The following is a description of a gene set: Any process that modulates the rate, frequency or extent of release of cytochrome c from mitochondria, the process in which cytochrome c is enabled to move from the mitochondrial intermembrane space into the cytosol, which is an early step in apoptosis and leads to caspase activation. Mouse Gene Set: GOBP_REGULATION_OF_RELEASE_OF_CYTOCHROME_C_FROM_MITOCHONDRIA species: Mus musculus, and this is the list of marker genes: Bax, Moap1, Opa1, Pycard, Trp53, Pdcd5, Mfn2, Hgf, Bcl2l11, Lmna, Mff, Prelid1, Psmd10, Wdr35, Avp, Ppif, Hrk, Bak1, Fxn, Mllt11, Higd1a, Nol3, Fas, Bad, Pdcd5-ps, Bnip3, Ghitm, Bik, Plaur, Bcl2l2, Tnfsf10, Bmf, Dnm1l, Bcl2l1, Plscr3, Bid, Prkn, Akt1, Pmaip1, Arrb2, Pink1, Gpx1, Gper1, Pla2g6, Parl, Mmp9, Bbc3, Triap1, Igf1, Fam162a